The following is a description of a gene set: Any process that activates or increases the frequency, rate or extent of vascular endothelial growth factor signaling pathway. species: Mus musculus Mouse Gene Set: GOBP_POSITIVE_REGULATION_OF_VASCULAR_ENDOTHELIAL_GROWTH_FACTOR_SIGNALING_PATHWAY, and this is the list of marker genes: Adgrg1, Jcad, Itgb1, Vegfa, Ccbe1, Itga5, Robo1, Adamts3, Vtn, Itgb3, Smoc2